The following is a description of a gene set: Any process in which a pigment granule is transported to, and/or maintained in, a specific location within the cell. species: Mus musculus Mouse Gene Set: GOBP_PIGMENT_GRANULE_LOCALIZATION, and this is the list of marker genes: Vps33b, a, Rab11b, Rab27a, Map2k1, Bloc1s3, Cdh3, Dctn1, Myo5a, Vps33a, Myo7a, Rab11a, Shroom2, Rab17, Bloc1s6 (biogenesis of lysosomal organelles complex-1, subunit 6, pallidin), Bloc1s5, Mreg, Rab1a, Mlph, Dctn2, Gpr143